The following is a description of a gene set: The process carried out by a cell that restores the biological activity of an unfolded or misfolded protein, using helper proteins such as chaperones. studied in species Homo sapiens Human Gene Set: GOBP_PROTEIN_REFOLDING, and this is the list of marker genes: CRYAA, HSPA7, HSPA8, DNAJA2, BAG5, HSPD1, FKBP1B, CRYAB, HSPA5, HSPA14, HSPA13, HSPA1L, HSP90AA1, HSPB2, SDF2, HSPA1A, SNRNP70, DNAJA1, HSPA1B, B2M, HSPA9, HSPA6, DNAJA4, HSPA2, DNAJB2, HSPB6, SDF2L1, FKBP1A, HSPB1